The following is a description of a gene set: Activated caspases cleave nuclear lamins causing the irreversible breakdown of the nuclear lamina. part of: Apoptotic cleavage of cellular proteins Reactome Pathway: Breakdown of the nuclear lamina studied in species Homo sapiens, and this is the list of marker genes: LMNB1 (lamin B1), CASP6, LMNA